Given this list of marker genes LDOC1, IPO7, ADCYAP1, EPC1, PIK3R5, MPHOSPH9, NFIA, PCNX1, PRR32 (proline rich 32), SLCO3A1, PSAP, ASAP2, QSER1, SLC24A2, KLF7, CCNL1, ARID4B, PKN2, BRAP, QRSL1, C5orf22, IQCH, KIF23, RFK, SEPTIN2, ATXN7, TOB1, ZNF213, OTULINL, ZBTB37, PAIP1, ARFGEF1, TMEM30A, TOM1L2, FIGN (fidgetin, microtubule severing factor), LUZP2, WNK1, LCOR, ULK2, SP1, ZFYVE16, IKBIP, ADAM9, SBF2, WNT5A, LOXL3, TMSB4Y, NPNT, CCDC6, RAB5A, PICALM, C2orf69, MB21D2, PLLP, ADAMTSL3, TMOD2 (NCBI Gene Id 29767), VPS13D, RAP1A, UBL3, IL6ST, MBD2 (NCBI Gene Id 8932), RFX7, RALGPS2, TMEM250, TMOD1, KMT2C, CDK19, NIPSNAP2 (nipsnap homolog 2), PAFAH1B1, RNASE11, SPOP, SYT9, OLFM3 (olfactomedin 3), CAMSAP1, PRX, EIF2AK1, FBN1, SPRED1, ADAM7, ARL5B, RANBP2, RAVER2, SLC25A40, CNOT2, CAPRIN2, MTMR12, TTYH1, here is a description of the gene set: Human Gene Set: MIR4473 Genes predicted to be targets of miRBase v22 microRNA hsa-miR-4473 in miRDB v6.0 with MirTarget v4 prediction scores > 80 (high confidence targets). from publication Chen Y, Wang X (PMID 31504780) species: Homo sapiens